The following is a description of a gene set: Genes up-regulated in PC3 cells (prostate cancer) after knockdown of EZH2 by RNAi. studied in species Homo sapiens from publication Nuytten M, Beke L, Van Eynde A, Ceulemans H, Beullens M, Van Hummelen P, Fuks F, Bollen M (PMID 17724462) EZH2 is a Polycomb group (PcG) protein that promotes the late-stage development of cancer by silencing a specific set of genes, at least in part through trimethylation of associated histone H3 on Lys 27 (H3K27). Nuclear inhibitor of protein phosphatase-1 (NIPP1) is a ubiquitously expressed transcriptional repressor that has binding sites for the EZH2 interactor EED. Here, we examine the contribution of NIPP1 to EZH2-mediated gene silencing. Studies on NIPP1-deficient cells disclose a widespread and essential role of NIPP1 in the trimethylation of H3K27 by EZH2, not only in the onset of this trimethylation during embryonic development, but also in the maintenance of this repressive mark in proliferating cells. Consistent with this notion, EZH2 and NIPP1 silence a common set of genes, as revealed by gene-expression profiling, and NIPP1 is associated with established Polycomb target genes and with genomic regions that are enriched in Polycomb targets. Furthermore, most NIPP1 target genes are trimethylated on H3K27 and the knockdown of either NIPP1 or EZH2 is often associated with a loss of this modification. Our data reveal that NIPP1 is required for the global trimethylation of H3K27 and is implicated in gene silencing by EZH2. Human Gene Set: NUYTTEN_EZH2_TARGETS_UP, and this is the list of marker genes: LYST, COL16A1, RNF7, TMEM140, CD59, LDAF1, MT2A, NUP62, FGF7, RNF2, ZDHHC21 (NCBI Gene Id 347748), RBM11, PSKH1, DRAM1, FHIP2A, MFSD12, LRPAP1, TRIM5, LUM, ANKRD37, FLVCR2, MAX, BBC3, LAMB3, PTGS2, MAP1B, PITPNB, APC2, DDX60L, CCDC126 (coiled-coil domain containing 126), MFSD14A, SERTAD1, SRPX2, ACE2, CDH11, SLC2A1, L3HYPDH, EIF5, IL6, RRAD, POLK, KRT34, XAF1, TMCC1, TENT2, GALNT1, GPER1, RIPK2, PRDX1, VASN, PARP14, LHFPL6, GLG1, MX1, TSPAN3, MAEA, KIAA0040, WDR1, FTMT, SP140, TMED10, YWHAZ, CMTM1, RAB27B, THBS1 (NCBI Gene Id 7057), GNAQ, SERPINB2, DNER, SELENOT, GHR, FMN2, CNIH3, KCNB1, TSPAN8, ERAP2, TCF4, FGD6, PAQR3, CXCL2, SAMD9L, HLA-E, CD69, NINJ1, ZBTB34, ACTR3, NMRK1, PCDH7, FGF1 (fibroblast growth factor 1), RRBP1, TMEM87A, HK2, GPRC5C, PHLDB2, CD47, SPTSSA (NCBI Gene Id 171546), PHF20L1, TCAIM, ITM2C, PKIB, TTC7B, FN1, ATG12, KCTD8, CTTN, KCNQ1, GBP4, PORCN, NR1D1, ADIPOR2, GPR155, BIRC3, CITED4, DNMT3B, RGS20, SRXN1, MAP2, TMTC2, MORC3, SRD5A1, CLTRN, BDKRB1, ROBO4 (NCBI Gene Id 54538), PNO1, MSI1, C1orf54, SMAD1, MIR22HG (NCBI Gene Id 84981), KLF4, NXPE3, TFG, MILR1, BAG2, NT5E, EVC, DHRS9, PSMB8, NFE2L1, SCP2, FUT8, NUAK1, P4HA1, HRK, CCDC167, EPSTI1, KIAA1217, STK39, DNAJA1, MREG, ZNF302, ADAM8, CFHR3, TFPI2, CCPG1, PSME2, ARL4C, ZNF121, RNF149, GRPEL2, ADRB2 (adrenoceptor beta 2), GJA1, PLAGL1 (PLAG1 like zinc finger 1), ZNF586, SLIT2 (slit guidance ligand 2), SHANK2, PODXL, AP1AR, CDC42SE2, CD58, PDP1, CISD2, IFITM1, NXT2, CLCN6, PPP2CA, PARP8, SLC15A4, TXNIP, SLC4A4, VGLL4 (NCBI Gene Id 9686), DTX3L, HSP90B1, PSMB9, APLN, TMEM145, MFAP1, PLEKHA4, TRIM22, SOCS5, EDN1, SHC3, ADAM17, SECTM1 (secreted and transmembrane 1), ITIH5, FDX1, THAP2, ITGB5, MGLL, ETS2, SLC37A3 (NCBI Gene Id 84255), XRN1, CDC42EP4, IGFBP3, GTPBP1, MEIS2, KRTAP1-5, MOSPD1, PABPC5, KLF3, C1R, WASHC4, BLCAP, CDC42SE1, HOMER3, SAR1A, IL24, CAP2, TGFBI, RRAS2, SLC18B1, ZMIZ2, PHLDA2, ABTB2, HLA-L, STAT1, B2M, AP3M1, RNMT, SERPINE2, BRI3, SLC35F3, SERP1, ICMT, AIM2 (NCBI Gene Id 9447), ARFGEF1 (NCBI Gene Id 25860), TCF7, TRIM21, GPX1, DDX60, SAA1, RBM25, CDC42EP3, TBC1D7, CDC42, NAMPT (NCBI Gene Id 10135), USP41P, CPED1, NCK1 (NCK adaptor protein 1), APOL6, NUP98, TMEM117, TLE4, PAQR7, OVOL1, ZFHX4, RETSAT, MARCHF4, OGFRL1, ESM1, PRKCE, AQP11, HLA-F, TMEM9B, GADD45A, ATF5, TRIM14, STK40, LOXL1, IL15RA, ZFP36L1, MOXD1, SLFN5, FAM162A (family with sequence similarity 162 member A), HCFC2, CCL26, GPR37, DGKD, RCAN1, BACE2, PLAAT2, SAT1, POMGNT2, MFSD1, NCOA7, KLK10, MATN2, RIGI, FYB1, EPHB2, MARVELD2, TNFAIP3, OXSR1 (oxidative stress responsive kinase 1), STT3B, CEMIP2, ZNF654, MT1X, NREP, PIP4K2A, BANK1, PLEKHA7, USP6, TNFSF10, DAGLA, B3GNT2, FIS1, TMEM109, SP100, COBLL1, MAT2B, RGMB, SPIN4, GRB10, BACH2, MXD1, PLEK2, CASP7, DNAJB9, GPR180 (NCBI Gene Id 160897), EGR1, BMF, TGM2, TMEM64, TMEM41B, CCDC88A, KIAA1191, QSOX1, ARID5B, WDFY1, SMYD3, ENTPD7, NIPSNAP2, SQSTM1, PBX3, CXCL8, RASGRP3, NEXN, GCNT2, GOLM2, AP1S2, WNT4, SLC37A2 (NCBI Gene Id 219855), FOXO1, IARS1, SPAG9, NIN, ICAM1, STC2, RPL23AP82, JAZF1, DLX2, MARCKS, HERC6, AXIN2, PLXNB2, ADAR, RND3 (Rho family GTPase 3), PAQR5, PANX1, SIPA1L3, ACOT2, VSTM2L, NMT1, TMEM106B, TMEM131, MMP13, PKIA, WFDC3, SERTAD4 (NCBI Gene Id 56256), GDF15, UBXN2A, CPQ, MYADM (NCBI Gene Id 91663), GLRX2, SNX21, LRATD1, OASL, ENDOD1, APOL3, SUGP2, TTC13, DNAL1, BNIP3, ATP6AP2, SERPINB7, AZI2, SH2D5, MAP3K14, CPNE8, MT1A, RBPJ, SEMA7A (NCBI Gene Id 8482), MGAT2, C11orf96, DIS3, CEACAM1, PRRG1, PALS1, SEMA3D, PAM, BMPR2, CCNJ, SERPINI1, FAM217B, LAMP3, LANCL1, PML, CREB5, LARP6, TSPAN9, PNRC1, DENND5A (DENN domain containing 5A), NR3C2, MATN3, SCARB2, CXCL1, DENND1B, PON2, PDK1, TMEM132A (NCBI Gene Id 54972), XRCC4, FASTKD2, SOAT1, EPHA7, INHBA, MAP2K1, CLDN1, TK2, ANXA1, GLB1, ANXA5, CMC1, NBN, ZFYVE26, MECP2, OSTM1, FRMD5, SCARB1, ANXA2, SLC1A3, SPSB1, HERPUD2, TMEM129, SPRED1, YOD1, ANKRD30B, E2F6, NMI, INSIG2, KBTBD8, LGMN, ACYP2 (NCBI Gene Id 98), CAST, CEBPB, LIPA, VAMP4, MMAA, EFR3A, KDM3A, DIPK1A, IRF6, FAM210A, TXNDC15, NT5C3A, GNA13, MEST, VEGFA, PARP9, SLC2A13, TMEM127, CLEC2B, SLC39A13, MLKL, GBP3, ROR1, MVP (NCBI Gene Id 9961), HMOX1, CLEC7A, CCR1, DEAF1, LIMA1, CDKL5, CNRIP1, SYNE3, S100A4, TTC19, SPHK1, APLP2, ANPEP, TM2D3, TCF20, TSPAN2, GATA6, PLEKHA3, POC1B, NTN4, STX6, RPS6KC1, GALNT3, SLC22A5, FUT11, ARL2BP, STX3, ABHD13, UCHL3, C5orf15, UBL3, ATP2A2, PTPRR, LRFN3, ATP6AP1, COL5A1, ZNF395, COPS5, HSF2BP, CAPRIN2, RP2, PLA2G4A, FBXL2, MT1G, SNX9, TRIM6, LNPEP, NEK6, NECTIN3, PPP2R5B, JARID2, CCNYL1, LMO2, BCL10, SUB1, KLHL20, RHOU, SAMHD1, GBP2, GTF2B, TAB2, TAPBP (TAP binding protein), TP53BP2, EGLN1, MRPS24, MYBBP1A, STYK1, RGL1, PTPRF, RAB8B, TRIM58, SYNC, TRIM25, QDPR, CAB39, CPA4, IL1B, TRAF1, PIP4P2, B4GALT5, CCDC117, PLA1A, NIPSNAP3A, RCN2, NLRP3, HSPA5, ABL2, MYO1E, IFIT5, SEC24D, PI3, IL32, PRNP, AGT, ANKFY1, PIK3CA, ANKRD10, FZD8, PELI3, SYNJ2BP, MT1E, PFKFB2, CYB561, CEP19, KIF1B, KIAA0513, LIMK1, ANXA4, RTP4, SERPINE1, GLIPR2, NETO2, HIRA, MKX, AQP3, FKBP1A, STOM (NCBI Gene Id 2040), DNAJB6, BTN3A3, SEMA3A, CD24, FBXO36, SGPP1, COLGALT2, FRMD6, STAT2, RAB42, HERPUD1, LAMA3, GRK5, NCS1, TGFB3, UBFD1, CHSY1, ACBD5, GUSBP4, KITLG, ASIC1 (NCBI Gene Id 41), PHF11, TNC, PEA15, ZFHX3, JPT1, CTH (NCBI Gene Id 63046), BATF2, ZNF614, RABEP1, PIK3CB, NHLRC3, MAPK6, TICAM1, SLC9A9, HLA-G (NCBI Gene Id 3135, major histocompatibility complex, class I, G), MAP7D2, BBS5, PAFAH1B1, ATF3, OXCT1, MXI1, PARP12, DDIT4, TPM1, NEURL1, IL6ST (interleukin 6 cytokine family signal transducer), IFNB1, ZNFX1, VEGFC, TAP1, TMEM14C, ARL5B, CLCN7, PLXNA1, VEZT, NR2F2, LNPK, COL6A1, DEPP1, TNIK, DNAJC16, AHNAK2, DNAJB4, FCHO2, NEMP1, STARD4, PLK2, CSF2, ADM, NDRG1, NFAT5, TGFBR2, RANBP3, KDM4C, CDKN1A (cyclin dependent kinase inhibitor 1A), MAL, ZHX1, MIA3, EIF5A2, OGT, SLC15A3, WARS1, NRP1, EFNA5, MALL, UBE2E2, JUNB, ERAP1, CGREF1, KCTD10, TEKT4, RTCA, KLF6, DYNC2I1, RNF114, WDR36, APOL2, LRRC8A, CTSB, NECAB1, RPS6KA3, SPTLC1, ARHGAP17, HMGA2, ABCA13, B4GALT6, UBP1, NCF2, APP, OSTCP1, SOCS1, KRTAP3-1, CKAP4, TRIM47, PPP1R3F, RBSN, EFEMP1, CA12, TLR2, CD44, C1orf116, DNMT3A, QKI, ARMC8, CLDN14, CTSC, LAMC2, TOR1AIP2, TSC22D2, CEP250, CEPT1, MMP3, RPN2, CCN3, ADAMTS14, GBP5, PPIF, UAP1, PPFIA4, KPNA5 (karyopherin subunit alpha 5), PXK, TMEM63B, SP140L, ZBTB1, IRF2, RBMS3, WBP1L, DUS1L, DCBLD2, LDHA, NT5C2, GFM2, UST, DUSP3, ARRDC3, SPATS2L, G0S2, AHRR, KRR1, SUSD4, UBE2L6, GULP1, ROBO1, PPP3CC, TYMP, DCUN1D4, TBC1D19, ERRFI1, REV3L, SGMS1, SHFL, EFHD2, FTH1P7, FTHL17, IDS (NCBI Gene Id 3423), ZNF404, PLD6, PLSCR1, SOD2, USP15, PTX3, MAN1A1, NFKBIA, TBK1 (TANK binding kinase 1), IFI44, ZC3HAV1, RUNX2, JUN (NCBI Gene Id 3725), EGR2, MCUB (mitochondrial calcium uniporter dominant negative subunit beta), ATP6V1A, DENND3, GEM (NCBI Gene Id 2669), HLA-C, SLC16A7, PSMF1, ABCA5, BHLHE40, LSS, DYRK3, SHISA2, MT1B (metallothionein 1B), NDUFA12, RFTN1, GLRX, TNFAIP8, MAB21L4, PRKAB2, RHOC, SLC25A36, SPINK6, CPEB2 (cytoplasmic polyadenylation element binding protein 2), RHOQ, C6orf141, ARRDC4, HLA-B, NOG, SELENOW, C1S, MCL1, PMAIP1, EHD1 (EH domain containing 1), WDR41, THSD1, BACH1, OSTC (oligosaccharyltransferase complex non-catalytic subunit), SORCS2, ATP1B1, MSRA, RESF1, KLC1, SAMD9, DYNLT1, TMEM38B, SGK1, PTPN1, GPR87, MOB3C (MOB kinase activator 3C), THUMPD2, PPT2 (NCBI Gene Id 9374), IL4I1, CYB5R1, CALU, PUDP, MYD88 (MYD88 innate immune signal transduction adaptor), PPM1K, CYLD, FNDC3B, RTP3, BLZF1, MCU, WDR26, ARL6IP1, ZCCHC2, USP18, FYTTD1, TLR3, ARHGAP21, DDIT3, JAK2, AKIRIN2, CCL20, MT1M, PFKFB4, TPI1, PHTF1, FNBP4, BAIAP2, ISG20, OAS3, ARMCX3, PROP1, CYB5A, CLN5, KLHL4, KCTD1, TPGS2, LACTB, LZTFL1, XKR8, TDRD7, RGS4, SETBP1, ASB2, PLOD2, GNAZ, FZD5, ZBTB47, HIVEP3, TMEM254, CHST7, CYTH1, LAP3, FGFBP1, EIF4EBP2, TENT5A, CORO1C, CLIC4, BACE1, PAPLN, ZDHHC3, RLF, SLC25A28, PPP1CB, PIGZ, ZSCAN32, FAS (NCBI Gene Id 355), TANK, ANGPTL4, SLC16A2, FLRT3, TUBB2A, ENO1, EIF2S1, ADAMTS6, IRF1, ADGRL1, AGPAT3, STRIP1, KLHL21, C15orf39, MXRA7, TPBG, ZNF704, FGF5, DCUN1D5, LCOR, OXTR, ANK1, TMC8, EIF2AK2, SLC16A3, GAS6, CA13, KMO, OAS1, BASP1 (NCBI Gene Id 10409), EEIG1, ZC3H12C, NOCT, DIO3, FGF7P6, OPTN, STEAP1, ARHGAP39, EPGN, ID2, C3orf52, PTP4A2, TMEM47, CHMP5, MRAS, NCOA3, NPTX1, FAM3C, SYNE1 (NCBI Gene Id 85448), SAP18, MAP3K13, ZFAND2A, PLAT, ARF3, MYEOV, P4HA2, SPEF2, HLA-H, DSE, S1PR1, SLC44A2, SLC31A2, TPCN1, GFPT2 (glutamine-fructose-6-phosphate transaminase 2), ST3GAL6, GCNT3, MRPS30, ADSS2, SCHIP1, C1GALT1C1, PTBP2, TNKS1BP1, SLC22A4, C15orf48, TMEM45A, AGRN, MRPS25, RPUSD4, LGALS8, RBBP6, LAMP2, FERMT2, IL6R, SPINK1 (NCBI Gene Id 6690), CD83, LGALSL, NFKBIE, SQOR, SECISBP2, CARD17P, THEMIS2, CCN2, IL1RAPL1, OAZ2, FLCN, MMP7, TRANK1, DCAF5, PPIC, USP42, HIVEP1, CFLAR, CLDN12, GPRC5B, CXCL10, DCUN1D3, DESI1, NID2, BIRC2, ATP6V1G1, MX2, CASP1, HMGCS1, COMMD10, IFI16, TMED5, ANKRD46 (ankyrin repeat domain 46), LGALS3, ZFP36L2, GMPR, BAG4, CSF1, LPXN (NCBI Gene Id 9404), APBB2, HERC5, WWC2, IFIH1, PSEN2, EDF1, NIBAN2, PNPT1, PRSS35, KCNAB2, BDNF